The following is a description of a gene set: Human Gene Set: GGCNNMSMYNTTG_UNKNOWN Genes having at least one occurrence of the highly conserved motif M123 GGCNNMSMYNTTG in the regions spanning 4 kb centered on their transcription starting sites. The motif does not match any known transcription factor binding site. from publication Xie X, Lu J, Kulbokas EJ, Golub TR, Mootha V, Lindblad-Toh K, Lander ES, Kellis M (PMID 15735639) studied in species Homo sapiens Comprehensive identification of all functional elements encoded in the human genome is a fundamental need in biomedical research. Here, we present a comparative analysis of the human, mouse, rat and dog genomes to create a systematic catalogue of common regulatory motifs in promoters and 3' untranslated regions (3' UTRs). The promoter analysis yields 174 candidate motifs, including most previously known transcription-factor binding sites and 105 new motifs. The 3'-UTR analysis yields 106 motifs likely to be involved in post-transcriptional regulation. Nearly one-half are associated with microRNAs (miRNAs), leading to the discovery of many new miRNA genes and their likely target genes. Our results suggest that previous estimates of the number of human miRNA genes were low, and that miRNAs regulate at least 20% of human genes. The overall results provide a systematic view of gene regulation in the human, which will be refined as additional mammalian genomes become available., and this is the list of marker genes: CDC42BPB, RALA, TET2, ELOVL5, PHF21B, SFXN1, CCDC71, WDR13, DDX5, ADAM11, ADNP, PLP2, HOXA1, LRMDA, PPP1CC, EEF1A1, CUEDC2, CLPB, KMT2A, BCAS3, EPC1, TOMM40L, PRRX1, ARCN1, CD4, CEP95, WDR81, HES6, PUM1, STRN3, GEMIN4, AP2M1, SEC31A, PAFAH1B1, HOXA2, MIOS, MIR22HG, TMEM9B, NFYC (nuclear transcription factor Y subunit gamma), CAMK1, RPL18A (ribosomal protein L18a), MEX3D, SPRY4, RPS8, EIF4A1 (NCBI Gene Id 1973), ATP6V0C, PCDHGB5, BAHD1, PCDHGB4, ACTR8, LUC7L3, RAB1B, REPS2, RAB1A, AP4S1, MAN1A1, SMYD5, OSBPL2, NASP, KCNN2, EIF4G2, ADGRL1, CD164, PIGV, YBX1, STK35, STAG1, KIF1B, NR4A2, SCRT2, RAD21, ZBTB40, SFPQ, UBE4B, CHTOP